Given this list of marker genes 1700012B09Rik, Disc1, Prkacb, Nphp1, Cep126, Ift20, Fank1, Ush1g, Ift88, Tulp3, Kcnq1, Cplane2, Prkar2b, Cfap36, Ift52, Cfap418, Pqbp1, Cibar1, Dync2i1, Rab8a, Prkaca, Traf3ip1, Enkd1, Cilk1, Ccdc42, Ift56, Mlf1, Ift57, Ift46, Mok (NCBI Gene Id 328160), Magi2, Dnali1, Invs, Odad2, Cluap1, Nek8, Cfap144, Ttbk2, Nphp3, Nphp4, Ift122, Dzip1, Spaca9, Clcn4, Kcnf1, Kcnj10 (potassium inwardly-rectifying channel, subfamily J, member 10), Dynlt2b, here is a description of the gene set: species: Mus musculus Mouse Gene Set: GOCC_CILIARY_BASE Area of the cilium (also called flagellum) where the basal body and the axoneme are anchored to the plasma membrane. The ciliary base encompasses the distal part of the basal body, transition fibers and transition zone and is structurally and functionally very distinct from the rest of the cilium. In this area proteins are sorted and filtered before entering the cilium, and many ciliary proteins localize specifically to this area.